The following is a description of a gene set: from publication Chen Y, Wang X (PMID 31504780) Mouse Gene Set: MIR_7001_5P Genes predicted to be targets of miRBase v22 microRNA mmu_miR_7001_5p in miRDB v6.0 with MirTarget v4 prediction scores > 80 (high confidence targets). species: Mus musculus, and this is the list of marker genes: Fndc11, Cthrc1, Slc25a10, Atg4b (autophagy related 4B, cysteine peptidase), Casc3, Rabl3, Mafb, Ubl5b, Jph2, Dagla, Btbd9, Vsx2, Heatr1, Col4a2, Zbtb37, Mdga1, Unc45a, Galnt2, Vars2 (valyl-tRNA synthetase 2, mitochondrial), 9930111J21Rik1, Rap1gap, Ttyh3, Stra6, Styxl2, Trp73, Arc, Epha8, Rin3, Abcd1, Crtc1, Fam120c, Nat8l, Bace1, Foxp4, Zbtb40, Dbndd1, Dip2c, Ubtf, Sox10, Esrrg, Dgkk, Rapgef2, Adgra2, Lrp4, Vangl2, Erf, Gja8, Bahd1, Acap3, Fxyd6, Impdh1, Fam163b, Trim46, Fbxl20, Plekho2, Susd6, Phldb1, Tfe3, G6pdx, Cacna2d1, Leng8, Prelp, Cd79a, Sv2a, Mapk4, Ifrd2, Dennd10, Eif5a, Ngef, Sfxn5, Hmgb1, Cbx5, Rnf44, Nfasc, Sel1l, Zmym3 (zinc finger, MYM-type 3), Hbegf, 2510039O18Rik, Etf1, Or10ad1c, Trappc9, Aip, Cilk1, 6430548M08Rik, Taf9b, Pear1, Grik3, Cyp2ab1, Rab43, Tubgcp4, Ddx3x, Dop1b, Ndrg1, Zc4h2, Kif21b, Adamts10, Pbx1 (NCBI Gene Id 98516), Hk1, Egr1, Slc25a23, Slc25a14, Cyp26b1, Cbx7, Ptpru, Plppr2, Vangl1, Mknk2, Gigyf1, Rimoc1, Cbfa2t3, Chrm1, Sarm1, Eeig1, Shisa6, Git2, Tsc1, 1700030J22Rik, Csdc2, Sptbn2, Tspan9, Plxna1, Kcng1, Mpz, Lrrc61, Tmem132e, Rcvrn, Aspm, Foxo4, Ewsr1, Gmip, Heph, Atp7b, Tbc1d25, Myrf, Ttc23, Stag1, Supt6, Tmprss3, Rps6ka2, Anpep, Tulp3, Cks1b, Ube2z, Zdhhc8, Slc25a46, Rbbp5, Nfix, Zfp710, Unk, Agpat1, Otud5, Tln1, Jade2, Zer1, Disp2, Mecp2, Eaf1 (ELL associated factor 1), Dchs1, Nptx1, Gpsm1, Myo1f, Gprc5b, Atg9a, Syvn1, Atxn7l3, Tmem127, Abcb11, P2rx2, Mindy1, Ube2m, Stard3nl, Strn, Smyd5, Efnb2, Micall1, Chad, Arid3b, Nucb1 (NCBI Gene Id 97355), Rgs7bp, Gse1, Pptc7, Cbx6, Sh3kbp1, Lingo1, Gtdc1, Myo1d, Itm2c, Mark2, Adamts1, Tmem104, Cdk16, Itsn1, Tom1l2, Vasn, Dolpp1 (NCBI Gene Id 93794), Ppp1r1b, Nectin1, Stmn2